Given this list of marker genes Pdpn, Mip, Has2, Inpp5k, Aqp9, Pkp1, Cftr, Aqp1, Slc4a11, Aqp2, Aqp6, Aqp5, Aqp8, Aqp11, Slc5a1, Mylk2, Aqp4, Aqp7, Slc14a1, Sctr, Hyal2, Ctns, Aqp3, Mllt6, Upk3a, Large1, here is a description of the gene set: The directed movement of water (H2O) into, out of or within a cell, or between cells, by means of some agent such as a transporter or pore. species: Mus musculus Mouse Gene Set: GOBP_WATER_TRANSPORT